Given this list of marker genes Serpine1, Dspp, Bmp4, Cebpb, Ipo7, Nfe2l1, Lef1, Ctnnb1, Bmp2, Msx1, Rptor, here is a description of the gene set: Mouse Gene Set: GOBP_REGULATION_OF_ODONTOBLAST_DIFFERENTIATION Any process that modulates the frequency, rate or extent of odontoblast differentiation. species: Mus musculus